The following is a description of a gene set: from publication Borjesson DL, Kobayashi SD, Whitney AR, Voyich JM, Argue CM, Deleo FR (PMID 15879137) species: Homo sapiens Polymorphonuclear leukocytes (PMNs) were obtained from healthy individuals in accordance with protocols approved by the Institutional Review Board for Human Subjects at the University of Minnesota and the National Institute of Allergy and Infectious Diseases. PMNs (107) were combined on ice with live S. aureus (108) or with live or heat-killed A. phagocytophilum (bacteria isolated from 5x106 infected HL60 cells for a ratio of 1 infected HL60 cell: 2 PMNs, ~ 5-20 A. phagocytophilum: PMN) in wells of a 12-well tissue culture plate (pre-coated with 20% autologous normal human serum). Unstimulated control assays received either buffer (for S. aureus comparisons) or clarified HL60 lysate (for A. phagocytophilum comparisons). Plates were centrifuged at 350 x g for 8 min at 4oC to synchronize phagocytosis and incubated at 37 deg. C in a CO2 incubator for the indicated times. At the indicated times, tissue culture medium was aspirated from the plate and PMNs were lysed directly with RLT buffer (Qiagen, Valencia, CA). Purification of PMN RNA and subsequent preparation of labeled cRNA target was performed as described in Methods. Labeling of samples, hybridization of cRNA with HU133A oligonucleotide arrays (Affymetrix, Santa Clara, CA), and scanning were performed according to standard Affymetrix protocols ( http://www.affymetrix.com/pdf/expression_manual.pdf ). Experiments were performed in triplicate, using PMNs from three healthy individuals for each treatment. Genes up-regulated in polymorphonuclear leukocytes (1.5h): control versus infection by A. phagocytophilum. Human Gene Set: GSE2405_0H_VS_1.5H_A_PHAGOCYTOPHILUM_STIM_NEUTROPHIL_UP, and this is the list of marker genes: ARHGEF10L, RAB13, WDR43, VTCN1, PSMB4, PPA1, OMP, CD53, DACT2 (dishevelled binding antagonist of beta catenin 2), S100A10, SERF1A, LAP3, SAT1, NOP10, CNIH3, CCDC172, FABP5, SFRP4, IGSF3, APBA2, LOXL1, WDR55, TTLL8, ALAS2, GPRC5C (NCBI Gene Id 55890), ILDR1, STEAP3, AXL, FMOD, LRP6, CPA2, TP53INP2, SELENOP, NDRG3, APCS, VSTM2L, MMP8, PRAMEF12, TSPAN31, CEBPZOS, TMEM176B, AQP1, TEX35, RHBDF2, ALDOA, TNNI2, NQO1, PRDM6, SLC46A2, MAB21L1, TAGLN, NCF2 (neutrophil cytosolic factor 2), CD200R1, HSPB2, C20orf96, SH2D4B, ATG5, EHD2, HRC, NTRK2, PGM1, APOC1, BOK, NXN, UNC119, S100A6, GALNT18, MAFB, S100A11, NDN, PRELP, NR1H3, OLFML2B, ITM2C, CAPG, CSTA, CTSC, PC, BOLA2, RYK, FCGRT, OSBPL10, BATF3, CFD, WNT2, NOL6, GRPR, KCNN3, NTF3, CTSB, PITHD1, MGP, SPIC, RBP1, CHCHD10, SPHK1, HINT1, COL1A2, NKD1, MISP, CD9, RAB3IL1, CMTM3, NEFM, KCTD8, CCL28, IL2RB, MYH11, ADHFE1, HADH, KBTBD3, OLFML1, LOXL4, RXRA, STAU2, FASN, VEGFC, SPON2, GNG12, EGFL7, LAMP1, IFIT3, IFITM2, PHLDA3, RASSF3, RNH1, DNAJB5, FAM25C, CST6, REXO2, CST3, SHMT1 (NCBI Gene Id 9316), SERPINB1, SLC25A4, SLIT1, SNX10, MMP23B, EGFR, SPTBN2, ANKRD45, HMMR, FAM241B, GPX3, RARRES2, C1R (complement C1r), ACTN3, EFNA3, PSMB3, SLC22A7, DSTN, TF, CCDC80, RIN2, IRF1, TMEM61, SNW1, COL3A1, HLA-C, CEBPA, SCUBE3, RCN1, MYH14, VWA5A, TSHR (thyroid stimulating hormone receptor), SNCA, SIX4, CFB, MAN2A1, PYROXD2, AMOTL2, GM2A, IFI27L2, S100A9, PSMB10, MRPL52, AUTS2, SCRN2, DTX4, HVCN1, USP18, AMBN, HBB, CTSV, PARD6G, TMEM256, NUPR1, HSPG2, KCNA7, MCFD2, AIF1, INPP5A, SLC35F1, PTPRJ, RAC3, PSMB9, ECEL1 (endothelin converting enzyme like 1), SLC7A4, CSTB, CPT1A, ATP5MK